Given this list of marker genes LINC00102, CD99P1, TSPY18P, RNU2-57P, TTTY7B, RNU6-521P, FAM197Y5, AMELY, RBMY2QP, IL3RA, TSPY19P, PPP2R3B, RNU6-941P, ENSG00000309903, TSPY10, RNA5-8SP6, TTTY23B, FAM197Y6, VDAC1P6, ATP5PFP1, USP9YP4, RNA5SP498, UBE2V1P3, TTTY11, TTTY1, RFTN1P1, TSPY11P, TTTY18, TTTY1B, LINC02968, TSPY13P, TSPY15P, ASMT (acetylserotonin O-methyltransferase), SRIP3, RPS4Y1, ASMTL-AS1, TTTY16, TSPY5P, AKAP17A, TTTY7, ZNF736P10Y, RBMY1A3P, LINC00106 (NCBI Gene Id 751580, long intergenic non-protein coding RNA 106), ZBED1, TSPY4, NAP1L1P2, TBL1Y, TSPY9, ZNF736P9Y, KRT18P10, PCMTD1P1, RNU6-1334P, TTTY12, GTPBP6, ZNF736P6Y, TOMM22P2, MTND2P3, TSPY25P, FAM197Y7, ZFY, USP9YP22, SHOX, FAM197Y9, MTND6P1, SERBP1P2, PCDH11Y, TUSC2P1, CDY3P, KRT18P53, FAM197Y3, RNU6-303P, SLC25A6, RBMY2GP, FAM197Y8, HSFY3P, DLGAP5P1, TSPY2, ZFY-AS1, LINC00278, TTTY22, TSPY16P, RNA5SP519, RBMY3AP, FAM197Y1, ZNF92P1Y, TTTY2, TSPY12P, MIR3690, CD99 (NCBI Gene Id 8279), ZNF736P7Y, PLCXD1, RNASEH2CP1, TSPY7P (testis specific protein Y-linked 7, pseudogene), DHRSX-IT1, P2RY8, GOT2P5, LINC03112, TTTY20, TTTY19, MTND1P1, TSPY24P, GPR143YP, RBMY2JP, TSPY6P, PRRC2CP1, ELOCP4, FAM197Y4, TTTY23, RNF19BPY, ZNF736P8Y, EIF4A1P2, ASMTL, USP12PY, RPL26P37, TTTY8B, LINC00280, TSPY8, FABP5P13, TSPY1, BPY2DP, RNA5SP518, RBMY2OP, TTTY2B, RBMY2NP, DHRSX, TSPY17P, XGY2, TTTY8, TSPY20P, CRLF2, CSF2RA, RBMY2KP, OFD1P3Y, MTCYBP1, SRY, TSPY3, RBMY2HP (NCBI Gene Id 378953), DUX4L31, FAM197Y2, TRIM60P3Y, PRKY, LINC00685, RPL14P5, AGPAT5P1, LINC00279, RN7SKP282, SNX3P1Y, CDC27P2, EEF1A1P41, MIR6089, TGIF2LY, here is a description of the gene set: Human Gene Set: chrYp11 studied in species Homo sapiens